Given this list of marker genes ASAH1, CD244, OCRL (NCBI Gene Id 4952), GPR101, HLA-B, FGG, ATP7B, OTULIN, TP53, ACP5, NFKBIL1, AIP, ANKH, IL6, HLA-DRB1 (NCBI Gene Id 730415), HGD, PTPN2, ANKRD55, GNB2, HFE, IL2RA, TNFRSF11B, IL10 (NCBI Gene Id 3586), BMP6, CCN6, TNFRSF1A, DDR2, PTPN22, LACC1, SLCO2A1, COL5A1, NOD2, COL1A1, SLC22A4, CIITA, TRAPPC2, SYK, FGA, STAT4, MEFV, CD247, CHEK2, BTNL2, IL1RN, RB1, COL5A2, HPGD, LPIN2, F8, MIF, IL2RB, FGB, here is a description of the gene set: species: Homo sapiens Human Gene Set: HP_JOINT_SWELLING Joint swelling